Given this list of marker genes H4C13 (H4 clustered histone 13), H2AC8, H2BC14, H2AC4, POT1, H2AC20, H2BC1, H2AC6, H2AC18, H2AZ2, H2BC10, H2AC14, H4C9, POLR2C, ATRX, POLR2A, H2AX, POLR2I, H2BC15, H2AC7, H2BC6, POLR2F, POLR2E, TERF2, H4C15, H2BC26, H2BC12, H3-3A, H2BC12L, H2BC13, H4C3, DAXX, H4C5 (H4 clustered histone 5), TINF2, POLR2K, H2BC3, ACD, H4C1, H2BC5, POLR2D, H4C6, H2AC19, H4C14, H2BC7, POLR2H, H4C2, TERF1, H4C16, H2AB1, POLR2J, H4C11, H4C12, H4C4, H2BC21, H3-3B, H2BC9, TERF2IP, POLR2B, H2BC17, H2AJ, POLR2G, POLR2L, H3-4, H2BC8, H4C8, H2BC11, H2BC4, here is a description of the gene set: Inhibition of DNA recombination at telomere studied in species Homo sapiens Human Gene Set: REACTOME_INHIBITION_OF_DNA_RECOMBINATION_AT_TELOMERE